The following is a description of a gene set: Genes having at least one occurrence of the highly conserved motif M29 CTTTAAR in the regions spanning 4 kb centered on their transcription starting sites. The motif does not match any known transcription factor binding site. Comprehensive identification of all functional elements encoded in the human genome is a fundamental need in biomedical research. Here, we present a comparative analysis of the human, mouse, rat and dog genomes to create a systematic catalogue of common regulatory motifs in promoters and 3' untranslated regions (3' UTRs). The promoter analysis yields 174 candidate motifs, including most previously known transcription-factor binding sites and 105 new motifs. The 3'-UTR analysis yields 106 motifs likely to be involved in post-transcriptional regulation. Nearly one-half are associated with microRNAs (miRNAs), leading to the discovery of many new miRNA genes and their likely target genes. Our results suggest that previous estimates of the number of human miRNA genes were low, and that miRNAs regulate at least 20% of human genes. The overall results provide a systematic view of gene regulation in the human, which will be refined as additional mammalian genomes become available. from publication Xie X, Lu J, Kulbokas EJ, Golub TR, Mootha V, Lindblad-Toh K, Lander ES, Kellis M (PMID 15735639) species: Homo sapiens Human Gene Set: CTTTAAR_UNKNOWN, and this is the list of marker genes: ASH2L, LYPD6, XPO7, MACO1, TBR1, IL1B, COPS6, EPAS1, ONECUT2, FAM169BP, RAB33A, RFX4, FAM27E5, TAOK1, GNAI1, POU2F1, CHAT, BIN1, PEX5L, RFTN2 (raftlin family member 2), HINT2, PFN2, ATOH1, ATP1A1, PHOSPHO1, ABRAXAS1 (abraxas 1, BRCA1 A complex subunit), DNAJC21, CACNG3, PDE10A, B4GALT1, CCNG2, APLP2, KLF8, PTMA, FGF16, FGFBP3, IKZF3, GCNT1, NME3, TGFB2, MIA2, TSGA10, HOXC13, SLC6A18, C12orf75, TMEM187, ALOX12, TGIF1, BCAS3, CAST, LGR5, QRICH1, DLG1, SMAD6, NOX3, GPR22, OR2A4, MFRP, PCGF1, TENM3-AS1, CLEC4D, RNF44, IGDCC3, EDEM1, STAG3, SOCS2, RCOR1, VASP, SCD, HMG20B, CACNA1A, RBX1, RHOBTB2, HPSE2, PDE3B, TXNL4B (thioredoxin like 4B), HOXD12, ALX1, RHOB, NHSL2, ENPP6 (NCBI Gene Id 133121), MB21D2, FEZF2, ZDHHC3, BMP2K, STOML2 (NCBI Gene Id 30968), PAK4, MAP1B, PAPPA, TSPAN3, TLCD3B, MCM7, MEA1, CALCRL, EN2, DMAC2, MRPL2, COLGALT1, GPR107, RUNX1T1, NCOA6, ZBTB22, FAM222B, MIR137HG, GAN, GNGT1 (G protein subunit gamma transducin 1), PRRX1, PXK, SEMA7A, BCL9, CDK14, PAX3, SERBP1, SNX15, ADAMTS6, PIK3C2B, FOXE1, FOXP2, NR2C2AP, LURAP1L, SMARCD2, ATRNL1, PHLDA2, DLG3, EN1, HIVEP1, NT5C1A (NCBI Gene Id 92409), CYP2W1, TPBG, GRPR (gastrin releasing peptide receptor), TNIP1, SON, INHBA, AZIN1, KTN1, ZNF366, RRM2, GMPR2, LRP5, TLCD4, TYRP1 (tyrosinase related protein 1), HPS3, EIF4A2, MRPS34, PNPLA6, OLIG1, RIPOR2, BLTP3A, SPRED1, CYP26B1, ARPIN, DOCK11, RDH10, PRIMA1, TCP10L3, AP4M1, IL1F10 (interleukin 1 family member 10), CBX6, RFX5, DLG2, AMBN, FUNDC1, BCL9L, CSF3, CNTLN, ZNF516-DT, DVL3, TFIP11, PIAS4, GATA6, CTNNB1, NKX6-1, LRRTM4, CEBPB, BORCS6, USP36, NUCB1, PORCN (NCBI Gene Id 65017), PPM1E, PCDH10 (protocadherin 10), RANGRF, BNC2, GPR21, ABCB1, NODAL, IL2, LDB3, PCYT2, IL1RAPL1, MEOX1, TCP10L, ARRDC3, SCML1, PIR, TMPRSS15, SUMO4, PRDM13, CIBAR1, GDAP1L1, PPP2R3A, SRSF2, PIGC, ARIH1, MCF2, SKAP1, C1orf43, KCNQ1DN, TBX4, HMCN1, TMEM241, MEPE, TMEM88, TMED1, ABCA7, HNRNPA3, ACE2, LIX1, TIAL1, EXOSC7, SPTLC3, ELMO2, PPP4R1, AGPAT1, PCDH9, MAP1LC3A, MMP17, MECOM, TCP11L2, LRATD1, ZBTB20, EYA1, TRPM3, ESRRG, HECTD2, CERCAM, DRG2, ANKRD28, POU4F2, SALL1, FAP, FES, ATP1A2, KLC4, SRPK2, HEXD, DPYSL2, TAGLN, PBX3, CLDN1, FXYD3, SSBP3, KLF3 (NCBI Gene Id 51274), TP63, CFL2, NTNG2, ZFP91, NSMCE3, PLAG1, CALN1, PRR14, SRSF9, FGF9, DCP1A, AGBL2, PROX1, SLITRK2, NFIX, ZNF367, OTX2, CDK8, TXNDC12, PATL1, NBPF11, HOXA3, LMOD1, FGF23, EMC2, NPPA, GRIK3, NRL, RABL6, IL9, BORCS5, KAT6A, SLC6A13 (NCBI Gene Id 6540), ATP6V0A1, ATF2, CA4, PEG3, TAFA1, AMER1, PIK3R3, NEDD8, RAB3C, SLC4A2 (solute carrier family 4 member 2), WDR49, TRPM1, SLC44A5, SSBP4, NCKAP5, MAB21L1, PLEKHA1, MYPN, TOP1, KNCN, PRRT1, FIP1L1, TUG1, MBNL2, ACTL6B (actin like 6B), UBE4B, JADE3, MAF, TMEM150A, NELL2, UGT2B10 (NCBI Gene Id 7365), MGAT4B, SUMF1, CHCHD7, SZRD1, PRPH, YBX3, CSPG4, NR3C2, STK35, ABCA10, ARMCX2, STX10, NRAP, PRDM1, SEPHS1, MED12, C2CD2L, HOXB7, SLC7A10, IRF2BP1 (interferon regulatory factor 2 binding protein 1), GRIA1, PHETA1, OR6C3, NXPH1, ZMYM6, PACSIN3, NR5A2, EDN1, NR2F2, SLC2A4, TMEM184B, SMC6, SLC36A2, TRERF1, STK40, CCN1, PPFIA2, CDH23 (NCBI Gene Id 7395), CNTN4, KCNJ8, NDST3, ZFYVE9, NSD3, NEUROD1, RAB15, ERICH6, SIK3, HYAL2, KRTAP13-2, EFHD1, EML4, TBX2, PDE6A, PRPSAP1 (phosphoribosyl pyrophosphate synthetase associated protein 1), CDK11A, UBR3, GPM6A, GIMAP1, RPS6KL1, GRIA3, REEP4, PTPN12, ODF1, YIPF1, BCL11B, CTBP2, PPP1R10, ZIM2, TIMELESS, NBEA, MEF2D, NRGN, SLC25A23, OPRM1, SORBS1, IGSF22, MBD5, ITGA3, FHL5, CPD, FBXL7, FBXO11, MNT, KLC2, EHF, MPP2, SALL2, HAS3, CRTAM, CDK16, SEC14L2, UBR4, XKRX, ZBTB33 (zinc finger and BTB domain containing 33), PMP22, PYROXD1, GRM7, DPF3, KLF3-AS1 (KLF3 antisense RNA 1), CCDC71L (coiled-coil domain containing 71 like), GEN1, PPARGC1A, RNF19A, SFRP1, KCNH5, INPP5F (NCBI Gene Id 22876), CNOT4, ALKBH5, LRRIQ3, SERTAD4, FOXG1, WNT5A, KLHDC3, TNNT2, C1orf122, ROBO1, WNT9B (NCBI Gene Id 7484), MATN3, OSBPL9, SLC9A6, TOPBP1, FLII, MYH2, OGA, OSR2, PMEPA1, SIX1, PHEX (NCBI Gene Id 5251), USP49, ITGBL1, AHCYL2, HOXD10, THOC6, ETHE1, MACROD2, PRDM16, SLC44A1, PISD, EXOSC6, DNAJC14, MAPKAPK3, FUT8, RPLP0, IER5, TAGLN2, NBL1, KCNH7, SLITRK4, ARHGAP6, TTC17, TCF4, PRKCG, CELSR2, MMP15, GALE, RNF5, SMARCB1, PAQR3, CLEC3A, SPRR2A, TBCC, MDM1, ACTR1B, SLC26A6, GCDH, CDIPT (NCBI Gene Id 10423), UBE2F, NOL12, HLA-B, ODAPH, NXN, CACNA2D3, RIMS2, NFKBIZ, NAMPT, ERRFI1, FOXO1, SKIDA1, OTOA, MSL3, PCDH18, VGF, INO80, BMP15, PLCL1, EPB41L5, GRPEL2, DUSP14, HNRNPLL, HOXB8, PDPN, PPP1R3A, SEL1L, ANKH, MYO18A, CIPC, NIPA2, YRDC, ATOH8, PRUNE1, CLDN11, FBXW7, NIPAL2, AKR1B1, GTF2A1, FKBP3, MEF2B (NCBI Gene Id 100271849), NEFM, PTH2R, EGLN3, ELF4, SLC25A48, UNC5B, KCTD8, OPHN1, SRF, EPYC, NSRP1, STC1, CPNE1, DPAGT1, GOLGA5, DBP, SRPX2, FBXO44, MED22, FOXB1, CLCA3P, CELF4, SIDT2, VCPKMT, ETV5, HOXA4, SMARCA1, CA7 (NCBI Gene Id 766), P3H2, HSP90AB1, CITED1, AHCY, FAM13B, SNPH, TP53BP1, ATP6V1E2, CHD4, SAYSD1, RFXANK, TEK, RTN4, ARHGAP5, DERL1, KCNJ5-AS1, IER2, SYNRG, PRRX2, SATB1, COQ8B, SLITRK1, ITPRIPL1, CLUH (NCBI Gene Id 23277), APLP1 (amyloid beta precursor like protein 1), TMEM163 (NCBI Gene Id 81615), ZMYM4, HTN1, ELAVL4, TCF7, NEDD4, SH3KBP1, CATIP, TSHZ1, IMMP2L, AMOT, MAP3K11, ERF, COLEC10, LARP1, PPP2R2B, SLITRK6, HNRNPD, FST, ERC1, FGF5, FXYD4 (NCBI Gene Id 53828), KDELR2, ELOA, SOX5, CDK7, ETF1, EIF2AK3, CYB561D1, IRAG2, LYG2, OPN3, PRRG2, MRTFA, CUX1, ADGRF1, SEMA3A, SRP72, PRUNE2, SPAG7, RCAN1, MAP2 (microtubule associated protein 2), EPC1, IDH1, IRAG1, SFXN2, NFATC4, KPNA6, CHRDL1, MKNK1, GPR174, AKTIP, ZNF710, LDB2, OTP, ABI2, SLC9A9, TLR7, MASP1, GNB4, ZIC2, KCNA3, NKX2-1, MRPS18B, TRMT9B, GPR63, PIP4K2A, TBX3, STIM2, LCOR, DLX1, CHRNA7, SLC1A3, PPFIA3, LMO4, TULP2, CS, KIF19, MAGI1, C12orf50, TECTA, MINDY2, YPEL5, MITF, KIRREL3, SNCAIP, ARL3, ITPKC, H2AX, SLC2A13, NKX2-5, AGPAT4 (NCBI Gene Id 56895), GLRX, TOX2, NASP, PPP2R5B, FOXN3, LYPD1, MIEF2, PELO, ITGA1, GNG11, GABPB2, ECM2 (NCBI Gene Id 1842), STX5, SOBP, MSX2, OGFOD3, TTC23, CALM1, BPNT2, THRB (NCBI Gene Id 7068), NDP, STEAP2, E2F3 (NCBI Gene Id 1871), NKAIN2, GNRHR2, JADE2, LMX1A, HDLBP, DSCAM, ASPN, PPP1R2B, LRRC28, FANCF, VAT1, TSHB, RIOK1, GDNF, SLC5A4, DHX38, SERPINF1, GPR50, MUSK, JAZF1, BIRC2, HAS2, MLLT6, FAM117B, CNTNAP5, EPC2, GRK5, PIGR, PELI2, MYL1, TUBAL3, SEMA3B, NREP, ACVR1C, TOB1, ANKRD7, PPT2, NLGN3, JMJD6, FABP4 (NCBI Gene Id 2167), MSI2, PRCC, TMCC1, KRT85, S100A10, SALL3, GOLPH3L, IKBKB, DUSP10, CTNNA3, HMBS, RPAP1, XK, NOL4, SGMS2, MYCL, VSTM2L, RAP2A, LIG3, EGF, C1QTNF7, MLN, NDST2, OGFOD1, MGAT4C, ZBTB7A, SLC25A21, PIF1, PYGM, RNF133, LBX1, COL9A1, AQP8, GCAT, IDH3A, GFRA3, MAMDC2, FKBP8, CSRP3, CAMK1G, CDC14A, WDR81, CREB5, DPH1, FOXQ1, PCF11, HCFC1R1, OGN, CMTM4, KCNH8, GIT1, USP31, PRKAR2B, CALCOCO1, MAPK10, CDK11B, PLCB3, IFT43, AKAP1, PITX2 (paired like homeodomain 2), SMIM14, MIR22HG, SIPA1L2, SERPINB10, PDIK1L, OLFML1, TFEC, CACNA1D, SLC6A5, SLC39A5, PPP1R14C, TSPAN31, DRD3, PDHA1, ANKRD10, XPO4, DGLUCY, DAB2IP, EMP1, EPB41, HROB, OMG, MEIS1, OTUB2, PHF12, TNFRSF19, PRDM12, CCR7, DMD, ETV6, BDNF, SSH3, ERBIN (erbb2 interacting protein), ADRB3, NPVF, ZNF362, PDGFRA, LINC02687, SUDS3, DTX1, CLIC3, C19orf25 (chromosome 19 open reading frame 25), CT55, SHH, IGF2R, LIN28A, ADGRD1, KLF5, ADAMTS5, RERE, BHLHE41, PI16, CLN3, PYM1, SLMAP (sarcolemma associated protein), MGAT4A, FAM20B, PLXDC2, NEUROD6, AFF3, KRT20, CDC37, PLA2G12B, WDPCP, HBP1, KRT222, DNAJA2, GMFB, AXL, SRC, GJA5, KBTBD12, PRKCE, SND1, ELAVL2, SFRP4, PDYN, CHD2 (chromodomain helicase DNA binding protein 2), ZNF593, PLP1, DUSP7, SLC25A37, YWHAG, SOX15, PRKACA, NAA50, KCNK12, ADD3, MACROH2A2, AMY2A, TCF7L1, PRKAG1 (NCBI Gene Id 5571), KDM5C, TGFB3 (transforming growth factor beta 3), SHANK2, JUND, NAALAD2, ZNF644, TSGA13, RBM41, CCER1, HOXD8, KLHL25, FOXD3, SHKBP1, IVNS1ABP, MAP2K5, CSDE1, BMP5, COL8A1, CALR, VASH1, PEX5, ARL6IP5, HOXA10, JARID2, C19orf73, IFRD1, KIF1B, COL6A3 (collagen type VI alpha 3 chain), NOSIP, SYNPO2L, ZNF219, PACSIN2, STK38L, EPHA1, PDE8A, MAP3K13, FMO3, CREB3L1, CLDN6, NAALADL2, LUC7L3, CCDC8, POLR1G, RBM24, TEKT4, NR2C2, PWWP3B, DIDO1, MEF2C, EPHA2, RASL11A, EMX2, PTGES2, PLCD4, LMNA, SPINK7, LMCD1, CDH20, ARL4C, DPP10, CHKA, GHDC, CSTA, IP6K2, FBXO2, LRRC36, FPGT, GPR158, HOXB3, ZFP36L1, SLC25A10, DCX, TRRAP, SPAG8, FEZ2, HIVEP3, ARID3B, CDKN2C, MFGE8, CYP4V2, GJC1, JMJD1C, ING2, BRPF1, STXBP6, CAMK4, HAPLN3, FOXI2, EP300, ZNRF2, PEX11B, MTMR11, VSNL1, F2RL1, ACTG2, JPH4, POLR3C, TMEM38A, NAGS, ZBTB18, PBX1, SYT12 (NCBI Gene Id 91683), INPPL1 (NCBI Gene Id 3636), RPL7, ADCYAP1, MACC1, ZNF365, CTNNBIP1, CCN4, LINC03042, RPL7A, PTK2B